Given this list of marker genes Ptprj, Rapgef1, Lyn, Ptprc, Appl2, Cd226, Rap1a, here is a description of the gene set: Mouse Gene Set: GOBP_POSITIVE_REGULATION_OF_FC_RECEPTOR_MEDIATED_STIMULATORY_SIGNALING_PATHWAY Any process that increases the rate, frequency or extent of the Fc receptor mediated stimulatory signaling pathway. species: Mus musculus